Given this list of marker genes CPXM1, MAP6D1, GRAMD4, USP33, AGMAT, DPEP2, P3H4, MAP3K20, APBB3, DRC7, AVL9, TECPR1, CLIC5, CTSF, MIR99AHG, ATG16L2, METTL2A, FAM8A1, RASA3, LDLRAP1, MEOX1, PI16, TSC22D3, ACSL3, CHST15, ZDHHC14, THG1L, FXYD1, here is a description of the gene set: Protective efficacy of Bacillus Calmette-Guerin (BCG) may be affected by the methods and routes of vaccine administration. We have studied the safety and immunogenicity of oral (PO) and/or intradermal (ID) administration of BCG in healthy human subjects. No major safety concerns were detected in the 68 healthy adults vaccinated with PO and/or ID BCG. Although both PO and ID BCG could induce systemic Th1 responses capable of IFN-gamma production, ID BCG more strongly induced systemic Th1 responses. In contrast, stronger mucosal responses (TB-specific secretory IgA and bronchoalveolar lavage T cells) were induced by PO BCG vaccination. To generate preliminary data comparing the early gene signatures induced by mucosal and systemic BCG vaccination, CD4<sup>+</sup> memory T cells were isolated from subsets of BCG vaccinated subjects pre- (Day 0) and post-vaccination (Days 7 and 56), rested or stimulated with BCG infected dendritic cells, and then studied by Illumina BeadArray transcriptomal analysis. Notably, distinct gene expression profiles were identified both on Day 7 and Day 56 comparing the PO and ID BCG vaccinated groups by GSEA analysis. Future correlation analyses between specific gene expression patterns and distinct mucosal and systemic immune responses induced will be highly informative for TB vaccine development. from publication Hoft DF, Xia M, Zhang GL, Blazevic A, Tennant J, Kaplan C, Matuschak G, Dube TJ, Hill H, Schlesinger LS, Andersen PL, Brusic V (PMID 28853442) species: Homo sapiens Human Gene Set: HOFT_CD4_POSITIVE_ALPHA_BETA_MEMORY_T_CELL_BCG_VACCINE_AGE_18_45YO_ID_7DY_TOP_100_DEG_EX_VIVO_UP Genes up-regulated in CD4-positive, alpha-beta memory T cell 7d vs 0d in adults (18-45) after exposure to BCG vaccine, time point 7D, administered ID (intradermal). Comment: top 100 most significantly altered genes comparing Day 0 and Day 7 responses directly ex vivo